Given this list of marker genes IGLV1-36, IGHV, IGKV1-12, FGR, IGKV5-2, IGKV1D-16, IGLC2, IGLC7, ARPC4, IGKV1D-39, DOCK1, BRK1, ITPR2, IGKV3D-20, LYN, MAPK3, IGLV1-40, IGLC1, MAPK1, BAIAP2, IGHG3, FCGR3A, IGHG1, MYH9, FCGR1A, IGHV3-13, IGLV, PIK3CB, PLD1, IGKV2D-30, IGKV1-17, IGHV3-53, IGKV2-30, IGLV8-61, IGKV2D-28, IGHV3-30, WIPF2, IGLV2-23, ITPR1, IGHV3-48, IGLV4-3, IGKV3-20, IGLV3-27, CD3G, ACTR2, IGKV2D-40, MYO5A, IGLC3, MYO1C (NCBI Gene Id 4641), MYO10, IGLV6-57, VAV3, IGLV2-8, IGHV4-59, PLCG1, IGHV3-9, HCK, IGLV3-19, PRKCD, PLCG2, IGLV1-47, GRB2, IGKV1-39, IGLV3-22, IGLC6, IGLV5-45, WAS, PLD4, IGLV3-16, IGLV4-60, IGKV1D-33, IGLV2-33, NCKIPSD, VAV2 (NCBI Gene Id 7410), LIMK1, ACTB, ARPC1A, IGKV3-11, IGHV4-39, CFL1, IGLV7-43, IGLV11-55, IGHG4, HSP90AA1, NCKAP1L, IGHV3-33, IGLV2-18, IGLV2-11, IGKV1D-12 (NCBI Gene Id 28903), PIK3R2, ELMO1, HSP90AB1, IGKV2-28, SRC, PLPP5, IGKV3-15, PLD2, IGHV3-11, IGKV1-5, VAV1, IGLV3-25, IGKV4-1 (NCBI Gene Id 28908), ACTR3, PTK2, MYO9B, ARPC2, ITPR3, ACTG1, RAC1, NCKAP1, IGHV1-46, ABI2, SYK, IGHV3-7, PRKCE, MYH2, WASF2, WASL, IGHV2-70, IGKC, PLPP4, PIK3CA, PLA2G6, CRK, ARPC1B, PLD3, IGHV4-34, ABI1, IGHV1-69, CD247, IGKV1-16, ELMO2, IGLV3-12, IGLV10-54, IGHG2, IGLV3-21, AHCYL1, IGKV1-33, CYFIP2, IGLV5-37, ARPC3, ABL1, YES1, WASF3, NCK1, IGKV2-29, CDC42, IGHV2-5, CYFIP1, ARPC5, FYN, WIPF3, IGLV4-69, PAK1, IGHV3-23, PIK3R1, IGLV1-51, BTK, WIPF1 (NCBI Gene Id 7456), NF2, IGHV7-81, IGHV1-2, IGLV1-44, WASF1, IGLV3-1, IGLV7-46, IGLV2-14, FCGR2A, here is a description of the gene set: part of: Innate Immune System species: Homo sapiens Reactome Pathway: Fcgamma receptor (FCGR) dependent phagocytosis Phagocytosis is one of the important innate immune responses that function to eliminate invading infectious agents. Monocytes, macrophages, and neutrophils are the professional phagocytic cells. Phagocytosis is a complex process involving the recognition of invading foreign particles by specific types of phagocytic receptors and the subsequent internalization of the particles. Fc gamma receptors (FCGRs) are among the best studied phagocytic receptors that bind to Fc portion of immunoglobulin G (IgG). Through their antigen binding F(ab) end, antibodies bind to specific antigen while their constant (Fc) region binds to FCGRs on phagocytes. The clustering of FCGRs by IgG antibodies on the phagocyte initiates a variety of signals, which lead, through the reorganisation of actin cytoskeleton and membrane remodelling, to the formation of pseudopod and phagosome. Fc gamma receptors are classified into three classes: FCGRI, FCGRII and FCGRIII. Each class of these FCGRs consists of several individual isoforms. Among all these isoforms FCGRI, FCGRIIA and FCGRIIIA, are able to mediate phagocytosis.